The following is a description of a gene set: studied in species Mus musculus The chemical reactions and pathways involving allantoin, (2,5-dioxo-4-imidazolidinyl)urea, an intermediate or end product of purine catabolism. Mouse Gene Set: GOBP_ALLANTOIN_METABOLIC_PROCESS, and this is the list of marker genes: Uox, Allc, Urah, Nt5c2, Ada, Nt5c, Gda, Xdh, Nt5c1b, Dnph1, Urad, Nt5c1a, Pnp